The following is a description of a gene set: Mouse Gene Set: REACTOME_LIPID_PARTICLE_ORGANIZATION Lipid particle organization studied in species Mus musculus, and this is the list of marker genes: Fitm2, Hilpda, Cidea, Fitm1, Hsd17b13, Cidec (NCBI Gene Id 14311)